The following is a description of a gene set: Mouse Gene Set: GOBP_NEGATIVE_REGULATION_OF_TUMOR_NECROSIS_FACTOR_MEDIATED_SIGNALING_PATHWAY species: Mus musculus Any process that decreases the rate or extent of the tumor necrosis factor-mediated signaling pathway. The tumor necrosis factor-mediated signaling pathway is the series of molecular signals generated as a consequence of tumor necrosis factor binding to a cell surface receptor., and this is the list of marker genes: Pias4, Gps2, Nr1h4, F2rl1, Tank, Traip, Ccdc3, Naip2, Peli3, Adipoq, Gas6, Xiap, Ppp2cb, Naip1, Apoa1, Dicer1, Cldn18, Tnfrsf11b, H2bc21, Naip6, Rffl, Ptpn2, Tjp2, Nol3 (nucleolar protein 3 (apoptosis repressor with CARD domain)), Birc7, Naip5